Given this list of marker genes CDKN1A (NCBI Gene Id 1026), MX1 (NCBI Gene Id 4599), ITGB4, ITGA7, IFITM1, GDF15, FASN, ERBB3, PTGES, RAC1 (Rac family small GTPase 1), PXN, here is a description of the gene set: from publication Whiteside MA, Chen DT, Desmond RA, Abdulkadir SA, Johanning GL (PMID 14737109) In recent years, most cDNA microarray studies of chemotherapeutic drug resistance have not considered the temporal pattern of gene expression. The objective of this study was to examine systematically changes in gene expression of NCI-H226 and NCI-H2170 lung cancer cells treated weekly with IC10 doses of cisplatin. NCI-H226 lung cancer cells were treated weekly with an IC10 dose of cisplatin. Candidate genes with a fold change of 2.0 or more were identified from this study. A second experiment was conducted by exposing NCI-H2170 cells to cisplatin doses that were increased in week 4 and decreased in week 5. Overall, genes were differentially expressed in both the NCI-H226 and NCI-H2170 cell lines. In the NCI-H2170 cell line, genes had a twofold gene expression change from weeks 3 to 4. Real-time PCR found a significant correlation of the gene expression changes for seven genes of interest. This small time-ordered series identified novel genes associated with cisplatin resistance. This kind of analysis should be viewed as a first step towards building gene-regulatory networks. Human Gene Set: WHITESIDE_CISPLATIN_RESISTANCE_UP species: Homo sapiens Genes up-regulated in NCI-H2170 cells (lung cancer) upon induction of resistance to cisplatin.